The following is a description of a gene set: A discrete posterior fossa cerebrospinal fluid (CSF) collection that does not communicate directly with the fourth ventricle. Posterior fossa cyst species: Homo sapiens Human Gene Set: HP_POSTERIOR_FOSSA_CYST, and this is the list of marker genes: GDF6, ERCC5, CSPP1, FGFR2, POMT1, PUF60, VSX1, SNORD118, LARGE1, FKRP, FKTN, POMT2, ABAT, PDGFRB, DPH1, DPH2, WASHC5, PLCH1